Given this list of marker genes SLC30A1, RTP1, BCL2L1, IL10, CDK14, STMN2 (stathmin 2), VSTM4, ARFGAP3, HNF1A, BRICD5, GNS, ITGAM, CORO1C, FAM181B, LINC00937, SMIM3, AASS, CLIC3, LINC01098, MAP3K8, SLF1, CMIP, F2R, TMEM132B, GCLC, MEPE, DTNA, MARK1, AHNAK, LLGL2, SYT1, METRNL, SLC30A6, SETD3, C1orf174, DNAJB11, FGFBP3, PRR5 (NCBI Gene Id 86335), EPAS1, EPHX4, MFSD9, STAM, TMEM52, NICOL1, EOMES, MRC1, PARS2, DEFB114 (NCBI Gene Id 245928), FAM217B, TGIF1, ATP1B1, DYRK3, GFOD1, DND1, LSMEM2, GZMB, FAM236A, OR10A3, CYP4A11, RGS6 (regulator of G protein signaling 6), LPCAT1, DYNLRB2, ONECUT2, MYO1F, FAM43A, XCL1, PTGER2, PMS1, GNA15, SLCO5A1, SLX4IP, WDR35, GAB2, PLA2G7, CCL5, KCNA2, G6PD, IER5L, PRDM13, PLEKHF1, PTPRS, ATP2A2, MAP2K3, DOK7, C1orf226, CTLA4, DOK4 (NCBI Gene Id 55715), MEAF6, MAF, LPGAT1, TPBG, LLGL1, PTK2B, MFSD10, MMP8, EVL, RHEX, TIMP2, HPGDS, CLPTM1, UPP1, VCAM1, SPC24 (SPC24 component of NDC80 kinetochore complex), IGF2BP2-AS1, LRRC3B, CDCA7, STX3, AQP4-AS1, CCDC86, SSH1, RAPGEF4-AS1, IL17RB, NPVF, LINC01686 (NCBI Gene Id 284648), UBE2C, ALDH9A1, SLC41A2, ZBTB32, LGALS2, DSCR10, PLEKHA3, PCDH7, MISP3, TAF5L, NCR1, PTPN9, ABHD15, SNRNP48, MROCKI, FBXO31, TTTY13, ITIH2, C12orf50, PPM1L, EML6, C20orf181, NOVA2, GPX1, RBM15, CEP55, HLA-DRA, HHLA2, HIP1, SPATA32, HINT2, SNX30, HOPX, CTXN3, DPYSL4, LINC01096, PRKAA2, ADRB2, HES6, ADAMTS16, NEFM, H3C7, OR5E1P, CATSPERB, GALNT1, POGLUT2, UTP11, REEP4, F5, ENSG00000240207, BHLHE40, HLA-DPA1, DNMBP, COMMD7, WEE1, AATK, NDUFA4L2, FKBP11, BCL7A, KHDC1, NUSAP1, NPFFR2, CTNNA1, NUTM1, WWTR1, CDAN1, LINC00630, CRNDE, N4BP3, ARHGEF12, LSM14B, ZNF365, REXO6P, LRRC45, FHL2, PAWR, UBE2T, here is a description of the gene set: Genes up-regulated in comparison of CD4 effector memory T cells versus CD4 central memory T cells. studied in species Homo sapiens from publication Chevalier N, Jarrossay D, Ho E, Avery DT, Ma CS, Yu D, Sallusto F, Tangye SG, Mackay CR (PMID 21471443) Human Gene Set: GSE26928_EFF_MEM_VS_CENTR_MEM_CD4_TCELL_UP